The following is a description of a gene set: Mouse Gene Set: MIR_7003_5P from publication Chen Y, Wang X (PMID 31504780) studied in species Mus musculus Genes predicted to be targets of miRBase v22 microRNA mmu_miR_7003_5p in miRDB v6.0 with MirTarget v4 prediction scores > 80 (high confidence targets)., and this is the list of marker genes: Tmem35a, Dcakd, Erf, Pde1c, Hectd3, Atad1, Ogfod1, Tnfsf4, Slc7a1, Elavl3, Map3k9, Ski, Reg3g, Cyp4a12b, Cyp4a12a, Crybg3, Trarg1, Fchsd1, Pdgfra, Trim43b, Cdc42 (cell division cycle 42), Arl4d, Os9, Khdrbs1, Camk1g, Phf12, Ube2o, Hcfc1r1, Igf2, Asb13, Wdr12, Zfp942, Iqgap3, Gpr179, Dnaja2, Pax8, Vtcn1, Tmem250, Ppp1r9b, Nckap5l, Syndig1l, Dsc1, Hnf4a, Plp2, Stk32b, Elavl4 (ELAV like RNA binding protein 4), Nos1, Phf13, D430041D05Rik, Golph3l, Luzp1, Ier5, Aar2, Dmc1, Ddah1, Dspp, Irf3, Scamp4, Unc5b, Fhl3, Wars1, Tmem104, Pecam1, Celsr3, Carhsp1, Guca2b, Cd37, Ankrd10, Csrp1, Bbx (NCBI Gene Id 74503), Parva, Vwa1, Crppa, Rtp3, Lrrc15, 3110082J24Rik, Msn, Cd33, Ptpn21, Strip2, Endov, Zfp644, Ino80d, Sorcs2, Amd2, Dok4, Mex3a, Ttyh3, Cks1brt, Pip4p1, Ddx17, Myt1l, Plxnd1, Sytl4, Cts8, Stc1